Given this list of marker genes TRIT1 (tRNA isopentenyltransferase 1), CTAG1A, HSD17B10, CTAG1B, OSGEPL1, TRMT10C, LAGE3, TP53RK, TPRKB, METTL8, GTPBP3, MTO1, GON7, CDK5RAP1, YRDC, PUS1, RPUSD4, TRMT5, OSGEP, CTAG2, here is a description of the gene set: species: Homo sapiens Human Gene Set: GOBP_TRNA_THREONYLCARBAMOYLADENOSINE_METABOLIC_PROCESS The chemical reactions and pathways involving tRNA threonylcarbamoyladenosine, a modified nucleoside found in some tRNA molecules.